The following is a description of a gene set: species: Mus musculus A renal system process in which sodium ions are taken up from the collecting ducts and proximal and distal loops of the nephron. In non-mammalian species, absorption may occur in related structures. Mouse Gene Set: GOBP_RENAL_SODIUM_ION_ABSORPTION, and this is the list of marker genes: Oxsr1, Wnk4 (WNK lysine deficient protein kinase 4), Kcnq1, Maged2, Slc12a3, Klhl3, Guca2b, Ednrb, Stk39, Umod, Ednra, Kcnj1, Edn1